Given this list of marker genes PLAA, TAF1, BRAF, SEPSECS, TSEN54, RILPL1, TSEN34, TSEN15, TSEN2 (NCBI Gene Id 80756), NGLY1, LRP12, NOTCH2NLC, PMP22, GIPC1, here is a description of the gene set: Human Gene Set: HP_IMPAIRED_OROPHARYNGEAL_SWALLOW_RESPONSE Delay or absence of the swallow response, reflexes triggered by the contact the food bolus makes with the anterior faucial pillars. Impaired oropharyngeal swallow response species: Homo sapiens